Given this list of marker genes ADAM19, OTULINL, VAV2, CNTROB, CD82, IRF1, TGFB1 (transforming growth factor beta 1), SLC35C2, SEC14L1, TFR2, TCTA, TCAP, CD160, PC, TRGV11, ANXA6, TRIM47, NPDC1, OR2H2, ICAM5, AKR1B10, ABHD8, SLC22A4, TYROBP, AOC1, IL18, ITGAX, IL4I1, SIRT2, CD79B, CCNA1, GPSM3, CIDEC, KLRB1 (NCBI Gene Id 3820), ZNHIT3, SLC5A1, GIP, TM4SF5, ICAM2, CASP1 (NCBI Gene Id 834), RGS2, GGT5, CDKN2B, IL12RB2, IRF4, LY75 (NCBI Gene Id 4065), SLC11A2 (NCBI Gene Id 4891), DGKA, TGFBI, ITGAL, NFIA, DTX1, SIPA1 (NCBI Gene Id 6494), ATP1B1, GPX4, DNASE1, MGAT3, NCF1, SPIB, LPGAT1 (lysophosphatidylglycerol acyltransferase 1), UPP1, SST, EVI2A, CYB5A, GALM, ERO1B, ABR, CCL25, HLA-DOB, MCFD2, IGLV1-50, RUNX2, NR1H3, PCOLCE, LYL1, C4A, FABP1, SEPTIN4, CMBL, PAX8, NUMB, ZAP70, CD48, ENTPD2, SOAT2, DAO, DPT, PAPSS2, ATP6V0E2, MTF2, PRSS30P, SLC27A4, ARG2, GNPDA1, POU2AF1, TOB1, GSTK1, CYP4F8, HLA-B, PHETA1, CDK2AP2, CCR9, RBP2, HLA-DMB, AGR2, GPR89A, G6PC1, SDF4, LAT2, XDH, FAM3B, SEC14L2, ALB, GSTM5, VDR, LDB3, MTTP, EPHX2, CYP27B1, ADIPOR2, VAMP5, JCHAIN, ACOT13 (acyl-CoA thioesterase 13), PTPRC, OGDH, GNAZ, IGHG3, SLC22A18, PCDHA13, ZG16, CDKN2D, VAV1, GSTT1, SMPD2, PIK3CD, KEAP1, ADORA2B, DGAT1, RHOC, CYFIP2, CTSW, GNS, ENTPD5, SIRPA, CD53, BARX2, CNTNAP1, ABCC3, CD52, GHRL, AADAC, SLC6A4, DDR2 (discoidin domain receptor tyrosine kinase 2), ARHGDIB, SETDB1, TPH1, GDI1, NR1I3, GALNT10, LTB4R, IL12RB1, PLPP1, GZMB, ARHGAP45, CD5, MYO7A, JAK2, CYB5R3, RAC2, SLC4A5, SRGN, RDH16, CCL21 (C-C motif chemokine ligand 21), ACY3, IKBKE, MAPRE3, DDHD2, IGKV1-9, MOV10, KCNJ11, PCSK5, TNFRSF17, DHRS1, PPARA, RGS10, FLT4, CD79A, ZNF467, CYP2C8, CXCL13, ITGB7, CD8A, TMEM50B, IGHV1-2, IDO1, FCGBP, PTPRE, SULT2B1, CX3CL1, LIPA, CHPT1, PRLR, BTD, WDTC1, LRP1, ITGA3, ATP6V0A1, TP53INP2, ATP2A3, SLC5A11, FGD3, DDC, BMP4, MGST2, CCL5, SLC35B1, SELPLG, CD3D, SAR1B, BASP1, RFXANK, CD28, IL2RB, ATP6V0B, CIDEB, PRRG2, CDHR5, LTBP4, EDN3, FABP7, NAPSA, CAPN9, WBP2, SLC51A, REG1A, MOGAT2, RBP4, ICOS, PLD4, HIC1, MXI1, CD7, CAPN3, GCG, CHST2, CD302, ABCC2, GGT1, SLC2A2, CD22, TLL1, MAP3K1, SLC4A4, PIPOX, PDE9A, SRXN1, CLGN, MLPH, PAFAH2, C1QC, GIMAP4 (GTPase, IMAP family member 4), TCF21, KSR1, SLC7A8, IGHV4-39, ST3GAL4, LCT, ARSA, MGST3 (NCBI Gene Id 9272), COL4A5, CLCN2, NDFIP2, ST8SIA4, GZMA, CYP2S1, LAPTM5, RMDN3, MEP1B, MERTK, IFNA1, CXCL14, MIEN1 (migration and invasion enhancer 1), PRXL2A, INPP5D, SLC2A5, CCK, PLTP, CASP6, GPR12, PLEKHO1, IGLV4-69, GPD1, CGGBP1, MYT1L, HAGH, IGKV2D-30, RASSF2, IGLV2-18, ABCD1, ACE, CRAT, CUL4B, SLPI, CEACAM4 (CEA cell adhesion molecule 4), CD70, ITGAE, GNA11, EDN2, DPEP1, SPHK2, GRINA, SERPINB9, ALDOB, FAS, CORO1A, CMA1, ACOX1, ITGB2, COX7A1, SOD3, AAMDC, FMNL1 (formin like 1), NUB1 (NCBI Gene Id 51667), FLVCR2, CA4, STK10, ADH4, FLT3LG, ACAA1, NKIRAS1, TEP1, CDR2, ERCC5, CD72, TCEA3, TAX1BP3, RDH5, CST7, IGKV4-1, SYNPO, NPR3, PEPD, DNAJB9, IGHM, MYH14, CD6, PRPSAP1, SLC7A9, TRGC2, SOX18, MEIS2, DAB1, LSP1, RRAGD, CD2, CHRNG, GBP2, KLK1, REG3A, ANK3, S100A13, GBF1, ST6GAL1 (ST6 beta-galactoside alpha-2,6-sialyltransferase 1), FAHD1, MOCOS, ACP5, USP2, NBL1, ABCB9, here is a description of the gene set: from publication Sansom OJ, Reed KR, Hayes AJ, Ireland H, Brinkmann H, Newton IP, Batlle E, Simon-Assmann P, Clevers H, Nathke IS, Clarke AR, Winton DJ (PMID 15198980) studied in species Mus musculus Top genes down-regulated at day 5 of Cre-Lox induced APC knockout in the intestine. Although Apc is well characterized as a tumor-suppressor gene in the intestine, the precise mechanism of this suppression remains to be defined. Using a novel inducible Ahcre transgenic line in conjunction with a loxP-flanked Apc allele we, show that loss of Apc acutely activates Wnt signaling through the nuclear accumulation of beta-catenin. Coincidentally, it perturbs differentiation, migration, proliferation, and apoptosis, such that Apc-deficient cells maintain a crypt progenitor-like phenotype. Critically, for the first time we confirm a series of Wnt target molecules in an in vivo setting and also identify a series of new candidate targets within the same setting. Human Gene Set: SANSOM_APC_TARGETS_DN